Given this list of marker genes MCF2L, ARHGEF1, PIK3R1, STOM, ARHGEF17, FLOT2, ARHGAP32, NET1, ACTC1, ARHGEF12, ARHGEF2, STK10, VAV2, ARHGAP5, PKN1, VAMP3, ROCK2, SLK, ARHGAP35, PKN2, DAAM1, TFRC, ARHGDIG, SNAP23, CAVIN1, MCF2, MCAM, AKAP13, CAV1, RTKN, CIT, PREX1, STARD13, FLOT1 (NCBI Gene Id 10211), ARHGAP39, IQGAP3, ARHGEF28, MYO9B, TJP2, ARHGAP26, ROCK1, ARHGEF10L, BCR (NCBI Gene Id 729775), JUP, RACGAP1, RHOB, ABR, ANLN (NCBI Gene Id 54443), ARHGEF5, PIK3R2, ARHGEF11, OPHN1, ARHGEF10, RHPN2, SOWAHC, ARHGEF25, ARHGAP1, DLC1, VANGL1, PCDH7, MYO9A, ARHGAP21, ERBIN, DIAPH3, ARHGEF3, ECT2, DIAPH1, DEPDC1B (DEP domain containing 1B), PKN3, STARD8, here is a description of the gene set: Reactome Pathway: RHOB GTPase cycle This pathway catalogues RHOB guanine nucleotide exchange factors (GEFs), GTPase activator proteins (GAPs), GDP dissociation inhibitors (GDIs) and RHOB effectors. RHOB belongs to the RHOA subfamily of RHO GTPases and shares 85% sequence identity with RHOA and RHOC. Posttranslational modifications of the unique C-terminus of RHOB regulate its subcellular localization. Similar to RHOA and RHOC, RHOB regulates the cytoskeleton and plays a role in cell migration. RHOB plays a role in regulation of membrane trafficking, cell proliferation, cell adhesion, DNA repair, and apoptosis. RHOB-regulated cellular processes are important for the immune system function, pulmonary gas exchange, and angiogenesis and vascular function. RHOB has been implicated both as a tumor suppressor and as an oncogene in cancer. species: Homo sapiens part of: RHO GTPase cycle